The following is a description of a gene set: Localized hirsutism Abnormally increased hair growth with a localized distribution. species: Homo sapiens Human Gene Set: HP_LOCALIZED_HIRSUTISM, and this is the list of marker genes: FLNA, SLC25A12, RTL1, GNS, AFF4, TASP1, RPL10, ARID1B, WASHC4, PRMT7, PPP1R21, TBX15, PEPD, EP300, DLK1, CREBBP, CPOX, WNT4, TP63, MEG3, CKAP2L